The following is a description of a gene set: from publication Cui A, Huang T, Li S, Ma A, Pérez JL, Sander C, Keskin DB, Wu CJ, Fraenkel E, Hacohen N (PMID 38057668) studied in species Mus musculus Cytokines mediate cell-cell communication in the immune system and represent important therapeutic targets. A myriad of studies have highlighted their central role in immune function, yet we lack a global view of the cellular responses of each immune cell type to each cytokine. To address this gap, the authors created the Immune Dictionary, a compendium of single-cell transcriptomic profiles of more than 17 immune cell types in response to each of 86 cytokines (>1,400 cytokine-cell type combinations) in mouse lymph nodes in vivo. A cytokine-centric view of the dictionary revealed that most cytokines induce highly cell-type-specific responses. For example, the inflammatory cytokine interleukin-1β induces distinct gene programmes in almost every cell type. A cell-type-centric view of the dictionary identified more than 66 cytokine-driven cellular polarization states across immune cell types, including previously uncharacterized states such as an interleukin-18-induced polyfunctional natural killer cell state. Mouse Gene Set: CUI_MIGDC_IL4_RESPONSE_UP Genes positively differentially expressed in cell type: MigDC (migratory dendritic cell) upon treatment with cytokine: IL-4 in mouse lymph nodes in vivo., and this is the list of marker genes: Hmgb1, Cenpb (centromere protein B), Pfn1, Hfe, Lad1, Ube2l6, Slamf7, Cd9, Eno1 (NCBI Gene Id 269605), Stxbp6, Foxn3, Psap, Efhd2, Psme2b, Ctsz, Cyb5r3, Nme1, Gng12, Cst3, Lsm4, Ccl17, Zfand6, Mink1, Vopp1, Cfl1, Gsn, Aldh1a2, Basp1, Cnp, Apol7c